The following is a description of a gene set: A structural abnormality of the sperm head. Human Gene Set: HP_ABNORMAL_SPERM_HEAD_MORPHOLOGY studied in species Homo sapiens Abnormal sperm head morphology, and this is the list of marker genes: PMFBP1, CFAP69, SUN5, DNAH17, STRC, CCDC62, CFAP70, USP26, CT55, TTC29, ACTL7A, SPATA16, BRDT, TSGA10, CATIP, AURKC, ACR, FBXO43, CCIN, CYLC1, SPACA1 (sperm acrosome associated 1), GBA2, DPY19L2, C2CD6, GGN, ZPBP, CEP112, ACTL9, IQCN, CFAP91, ARMC2, CATSPER2, TEKT3